The following is a description of a gene set: Human Gene Set: GOMF_INTERMEDIATE_FILAMENT_BINDING species: Homo sapiens Binding to an intermediate filament, a distinct elongated structure, characteristically 10 nm in diameter, that occurs in the cytoplasm of higher eukaryotic cells. Intermediate filaments form a fibrous system, composed of chemically heterogeneous subunits and involved in mechanically integrating the various components of the cytoplasmic space., and this is the list of marker genes: NES, SIRT1, SYNM, PKP1, KRT14, FAM83H, VIM, EPPK1, PKP2, MTM1, KRT74